Given this list of marker genes TERF1, NAT10, GNL3L, TENT4B, XRN1, TERF2, ACD, PARP3, HNRNPC, POT1, TP53, TEN1, EXOSC10, TINF2, HNRNPA1, STN1, HNRNPU, DCP2, PML (NCBI Gene Id 5371), PINX1, PIF1, CTC1, here is a description of the gene set: species: Homo sapiens Any process that stops, prevents, or reduces the frequency, rate or extent of the addition of telomeric repeats by telomerase. Human Gene Set: GOBP_NEGATIVE_REGULATION_OF_TELOMERE_MAINTENANCE_VIA_TELOMERASE